The following is a description of a gene set: species: Homo sapiens Signaling by FGFR2 in disease Human Gene Set: REACTOME_SIGNALING_BY_FGFR2_IN_DISEASE, and this is the list of marker genes: FGF17, POLR2G, POLR2B, POLR2I, GAB1, FGF3, NRAS, PIK3CA, PIK3R1, POLR2E, FGF20, NCBP1, FGF6, FGF1, GTF2F1 (general transcription factor IIF subunit 1), NCBP2, SOS1, FGF18, FGF22, POLR2L, POLR2K, FGF5, FGF23, FGF9, FGF7, GRB2, KRAS, PLCG1, POLR2D, GTF2F2, FGF8, FGF10 (NCBI Gene Id 2255), POLR2F, POLR2C, POLR2A, FRS2, FGFR2 (fibroblast growth factor receptor 2), FGF16, FGF4, HRAS, POLR2J, FGF2, POLR2H